Given this list of marker genes POLQ, RAD52, LIG3, MRE11, RAD50, XRCC1, FEN1, BRCA2, PARP2, RBBP8, NBN, PARP1, here is a description of the gene set: studied in species Homo sapiens Homology directed repair (HDR) through microhomology-mediated end joining (MMEJ) is an error prone process also known as alternative nonhomologous end joining (alt-NHEJ), although it does not involve proteins that participate in the classical NHEJ. Contrary to the classical NHEJ and other HDR pathways, homologous recombination repair (HRR) and single strand annealing (SSA), MMEJ does not require ATM activation. In fact, ATM activation inhibits MMEJ. Therefore, MMEJ may be triggered when the amount of DNA double strand breaks (DSBs) overwhelms DNA repair machinery of higher fidelity or when cells are deficient in components of high fidelity DNA repair.<p>MMEJ is initiated by a limited resection of DNA DSB ends by the MRN complex (MRE11A:RAD50:NBN) and RBBP8 (CtIP), in the absence of CDK2-mediated RBBP8 phosphorylation and related BRCA1:BARD1 recruitment. Single strand DNA (ssDNA) at resected DNA DSB ends recruits PARP1 or PARP2 homo- or heterodimers, together with DNA polymerase theta (POLQ) and FEN1 5'-flap endonuclease. In a poorly studied sequence of events, POLQ promotes the annealing of two 3'-ssDNA overhangs through microhomologous regions that are optimally 10-19 nucleotides long. Using analogy with POLB-mediated long patch base excision repair (BER), it is plausible that PARP1 (or PARP2) dimers coordinate the extension of annealed 3'-ssDNA overhangs via POLQ-mediated strand displacement synthesis with FEN1-mediated cleavage of the resulting 5'-flaps. The MRN complex subsequently recruits DNA ligase 3 (LIG3) bound to XRCC1 (LIG3:XRCC1) to ligate the remaining single strand nicks (SSBs) at MMEJ sites.<p>Similar to single strand annealing (SSA), MMEJ leads to deletion of one of the microhomology regions used for annealing and the DNA sequence in between two annealed microhomology regions. MMEJ, just like classical NHEJ, can result in genomic translocations. In addition, since POLQ is an error-prone DNA polymerase, MMEJ introduces frequent base substitutions. Reactome Pathway: HDR through MMEJ (alt-NHEJ) part of: Homology Directed Repair